Given this list of marker genes BHLHE40, CDKN1B, SLC2A1, DEPP1, HOXA5, MUC1, HOXA4, SAP30, DDIT4, HNRNPA1, F3, JUNB, PFKFB4, SLC2A3, JMJD6, EFNA1, BNIP3, TGFA, AK4, FOSL2, PHC2, PPP1R3C, VEGFA (NCBI Gene Id 7422), CDKN1C, NFIL3, RASGRP1, ADORA2B, KDM3A, PFKP, DUSP1, CCNG2, P4HA1, ALDOA, P4HA2, SERPINE1, STC2, PGK1, PDGFB, SLC16A3, SLC7A5, PLIN2, here is a description of the gene set: Epithelial cells of the kidney represent a primary target for hypoxic injury in ischemic acute renal failure (ARF); however, the underlying transcriptional mechanism(s) remain undefined. In this study, human proximal tubular epithelial cells (HK-2) exposed to hypoxia in vitro demonstrated a non-lethal but dysfunctional phenotype, closely reflective of the epithelial pathobiology of ARF. HK-2 cells exposed to hypoxia demonstrated increased paracellular permeability, decreased proliferation, loss of tight junctional integrity, and significant actin disassembly in the absence of cell death. Microarray analysis of transcriptomic changes underlying this response identified a distinct cohort of genes with a closely shared hypoxia-dependent expression profile. Within this hypoxia-sensitive cluster were genes identified previously as hypoxia-inducible factor-1 (HIF-1)-dependent (e.g. vascular endothelial growth factor and adrenomedullin) as well as genes not previously known to be hypoxia-responsive (e.g. stanniocalcin 2). In hypoxia, HIF-1 bound to evolutionarily conserved hypoxia-response elements (HRE) in the promoters of these genes as well as to the HRE consensus motif. A further subset of these genes, not associated with transcriptional regulation by HIF-1, was also present, suggesting alternative HIF-1-independent pathways. Overexpression of HIF-1 alpha in normoxia induced the expression of a significant number of the hypoxia-dependent genes; however, it did not induce the pathophysiologic epithelial response. In summary, hypoxia-elicited alterations in renal proximal tubular epithelial cells in vitro closely resemble the epithelial pathophysiology of ARF. Our data indicate that although this event may rely heavily on HIF-1-dependent gene transcription, it is likely that separate hypoxia-dependent transcriptional regulators also play a role. studied in species Homo sapiens from publication Leonard MO, Cottell DC, Godson C, Brady HR, Taylor CT (PMID 12885785) Genes up-regulated in HK-2 cells kidney tubular epithelium) under hypoxia and down-regulated on re-oxygenation. Human Gene Set: LEONARD_HYPOXIA